Given this list of marker genes DOCK1, LIMS2, CRK, TRIOBP, OLFM4, DAB2, FLNA, FGB, RAC3, MDK, MYADM, DOCK5, ARPC2, FERMT2, NEDD9, CSPG5, HTN1, P4HB, ARHGEF7, TESK1, ILK, CDC42, CALR, CASS4, NRP1 (neuropilin 1), CRKL, CARMIL1, HAS2, APOA1, ITGB3, FGG, BRAF, ABL1, S100A10, C1QBP, MYOC (myocilin), CIB1, PREX1, RAC1, RREB1, UNC13D, FGA, LIMS1, here is a description of the gene set: Any process that activates or increases the frequency, rate or extent of substrate adhesion-dependent cell spreading. species: Homo sapiens Human Gene Set: GOBP_POSITIVE_REGULATION_OF_SUBSTRATE_ADHESION_DEPENDENT_CELL_SPREADING